The following is a description of a gene set: Mouse Gene Set: GOMF_DEOXYRIBONUCLEASE_I_ACTIVITY Catalysis of the endonucleolytic cleavage of DNA to 5'-phosphodinucleotide and 5'-phosphooligonucleotide end products. studied in species Mus musculus, and this is the list of marker genes: Dnase1l1, Dnase1l2, Dnase1, Dicer1, Dnase1l3